The following is a description of a gene set: studied in species Homo sapiens Neighborhood of MYL3 myosin, light chain 3, alkali; ventricular, skeletal, slow in the GNF2 expression compendium Neighborhood of MYL3 Human Gene Set: GNF2_MYL3, and this is the list of marker genes: MYL3, HRC, TNNT2, NKX2-5, NPPA, COX7A1, PTP4A3, NMRK2, FABP3, COX6A2, ACTC1, SYNPO2L, MYL2 (NCBI Gene Id 4633), HSPB7, SGCA, MYL7, TNNC1, MYH6, FHL2, CKMT2, POPDC2, CASQ2, AK1, CSRP3, MYOZ2 (myozenin 2), TNNI3 (NCBI Gene Id 7137), MYH7, SLC4A3, DES, MYBPC3, PGAM2